The following is a description of a gene set: studied in species Mus musculus Mouse Gene Set: WP_HFE_EFFECT_ON_HEPCIDIN_PRODUCTION Hfe effect on hepcidin production, and this is the list of marker genes: Id1, Hjv, Smad7, Hfe, Hamp, Tmprss6